Given this list of marker genes B4galt1, Jup, Uba1, Tchp, Dsg1b, Pkp4, Pkp2, Pof1b, Pkp1, Dsp, Vcl, Pnn, Ppl, Kazn, Klhl24 (NCBI Gene Id 98030), Dsg4, Dsg1c, Evpl, Dsg1a, Ctnna3, Xirp1, Pkp3, Perp, Dsg2, Jam3, Cdsn, Dsc3, Dsg3, Dsc1, Cdh1, Dsc2, Cdh2, here is a description of the gene set: studied in species Mus musculus A cell-cell junction in which: on the cytoplasmic surface of each interacting plasma membrane is a dense plaque composed of a mixture of intracellular anchor proteins; a bundle of keratin intermediate filaments is attached to the surface of each plaque; transmembrane adhesion proteins of the cadherin family bind to the plaques and interact through their extracellular domains to hold the adjacent membranes together by a Ca2+-dependent mechanism. Mouse Gene Set: GOCC_DESMOSOME